The following is a description of a gene set: Transcription factors and DNA binding proteins enriched at promoters of genes whose expression fluctuates during the cell cycle (pVal < 0.05) and peak in G2 in K562 Transcription regulation during the cell cycle is crucial for ensuring genes are expressed at the right time and in the correct amounts, coordinating key processes like DNA replication, mitosis, and cell division. In our study, Human Gene Set: PULVER_FOREY_CELLCYCLE_ENRICHED_TFS_G2 studied in species Homo sapiens, and this is the list of marker genes: ZNF407, ZNF41, FOXA3, SKIL, GABPA, ZNF382, ETS1, TAF7, AFF4, ZNF202, EGR2, POLR2H, BACH1, EGR1, SOX6, TAF9B, SAP30, UBTF, MXD1, POLR2G, HMG20A, MTA1 (metastasis associated 1), GLIS1, NFIC, ZNF311, E4F1, NR2F2, ZNF431, GTF2E2, ZEB2, RBFOX2, ZNF322, ZNF165, NR3C1, ADNP (activity dependent neuroprotector homeobox), FOSL1, PHF8, ZBTB40, SMAD5, ATF3, SP4, TCF7L2 (NCBI Gene Id 6934), ZNF354B, MEIS2, TAF15 (NCBI Gene Id 8148), THAP12, SMC3 (NCBI Gene Id 9126), FOXK2, ZBTB26, CUX1, THRB, HDAC1, STAT5A, E2F6, ZNF749, HES1, DEAF1, ETV6, NFRKB, CDC5L, E2F4, NR2C1, ZNF148, ZNF175, FOXK1, ERF, KLF6, HSF4, RBM22 (RNA binding motif protein 22), OTX1, CREB3L1, GATAD2A, SP1 (NCBI Gene Id 6667), ZNF574, BRD4, NKRF, E2F5, TEAD4, FOXP1 (NCBI Gene Id 87246), KAT7, TRIM28, ZNF644, ZNF468, ZKSCAN5, CSDE1, CREB1, ZNF263 (zinc finger protein 263), CREM, ZNF507, NR2F1, TOE1, ARID2, NBN, SREBF1, ZKSCAN1, NFATC3, RAD51, ZNF609, GATA1, ZNF583, JUNB, CHD1, ZSCAN29, TFCP2, PRPF4, SMARCC2, MIER1, TFAP4, ZBTB43, ZNF740, MLX, SIRT6, ZSCAN16, ZNF766, ZNF444, SUPT5H, ESRRA, PRDM10, ARNT, PHF20, GATA2, MNT, ZNF3, NCOR1, ZNF384, MEF2D, MAFK, HDAC2, SMAD3, KLF13, KLF12, NFYB, DACH1, ELF4, ZNF24, ATF2, PCBP1, SIN3A, MEF2A, REST, PRDM9, CTBP1, NR2F6, FOS, IKZF1, ZSCAN22, GABPB1, MYNN, ATF6, TEAD1, SMARCE1, CEBPG, KDM1A, AGO1, SIN3B, CBFA2T3, HLTF, SRF, NRF1, USF2, ZNF318, RREB1, ARID3A, DIDO1, ASH1L, ZNF274, SRSF3, KDM4B, SUZ12, IRF9, TCFL5 (NCBI Gene Id 10732), ZNF639, RBM25, PML, ARID4B, RLF, CBX1, ID3, ZNF35, HCFC1, KDM5B, PHF21A, ZKSCAN8, BHLHE40, MAFF, FIP1L1, IRF2, LARP7, ZBTB7A, RUNX1, RNF2, ZBTB48, FOXM1, ZBTB33, RBM39, RELA, SPI1, THAP1, CHD2, MBD2, ZNF30, BCL6, EGR3, HMBOX1, TRIM24, KAT2B, ZNF764, ZNF641, CBFB, TAF1, ZNF134, ZSCAN32 (NCBI Gene Id 79229), ZBTB11, ZBTB9, ZHX1, ELF2, VEZF1, TRIM25, ZNF783, CTCFL, NFE2, RB1, DDX20, ZNF584, HDAC8, ZNF395, E2F1, GMEB1, ELF1, ATF4, DMBX1, SMAD4, LCOR, PKNOX1, ZNF511, ZNF76, ZNF334 (zinc finger protein 334), MTA3, RAD21, ARID1B, MTA2, PTBP1 (polypyrimidine tract binding protein 1), ZNF586, ZMIZ1, ZNF12, TBX18, CBFA2T2, EP400, FUS, GATAD2B, MYC, MITF, ZNF143, NONO, NEUROD1, HMGXB4, FOXJ2, EMSY, RBBP5, BMI1, RCOR1, SMARCA5, STAT6, ZNF316 (NCBI Gene Id 389461), YY1, CEBPZ, HNRNPLL, NCOA1, MLLT1, TBPL1, TFDP1, GTF2I, DPF2, TBL1XR1, CCNT2, HNRNPL, E2F8, L3MBTL2, ZNF592, ETV5 (ETS variant transcription factor 5), ZFP91, ZNF793, DMTF1, ATF1, BRD9, GTF2F1, HNRNPK, USF1, ETV1, POLR2A (NCBI Gene Id 5430), HBP1, ZFX, JUND (JunD proto-oncogene, AP-1 transcription factor subunit), TCF12, BCOR, MXI1, ZNF324, MYBL2, ZNF587, ZNF79, ATF7, KLF15, HMGN3, SP2, PHB2, EP300, ZIC2, PBX2, IRF1, NFYA, TAL1, ZBTB2, GTF3C2, ZFP64, ZNF215, CXXC5, CBX3, ZNF281, BCLAF1, TCF3, POU5F1, ZBTB1 (NCBI Gene Id 22890), YBX3, RFX1, MAZ, JUN, CEBPB, ZNF7, LEF1 (NCBI Gene Id 51176), RBM4, POLR2B, ZNF317, KLF1, ZNF239, NR4A1, ZNF197, U2AF1, XRCC5, SMARCA4, CREB3, RHOXF2B, E2F3, SCRT1, ZNF83, AFF1, SAFB, ELK1, TCF7, GTF2A2, TARDBP, PTTG1, TBP, SMAD1, ZBTB17, ZNF589, MAX, TFE3, PCBP2, KLF16 (NCBI Gene Id 83855), SIX5, ZNF282, CTCF, NR2C2, ZC3H8, ZBTB14, ZNF184, ZBED1, HDGF, ZNF554, ZBTB12, TCF15, CC2D1A